Given this list of marker genes Spon1, Sphk1, Pgk1 (NCBI Gene Id 214853), Ormdl1, Hap1, Rock1, Rtn3, Apoe, Sorl1, Rtn2, Abca7, Clu, Rtn4, Pin1rt1, Ormdl3, Ormdl2, Rtn1, Ntrk2, Rps23rg1, Bin1, Pin1, Prnp, Gga3, Igf1, here is a description of the gene set: studied in species Mus musculus Any process that stops, prevents, or reduces the frequency, rate or extent of the chemical reactions and pathways involving amides. Mouse Gene Set: GOBP_NEGATIVE_REGULATION_OF_AMIDE_METABOLIC_PROCESS